The following is a description of a gene set: studied in species Mus musculus from publication Rashi-Elkeles S, Elkon R, Weizman N, Linhart C, Amariglio N, Sternberg G, Rechavi G, Barzilai A, Shamir R, Shiloh Y (PMID 16314843) Mouse Gene Set: RASHI_RESPONSE_TO_IONIZING_RADIATION_5 The ATM protein kinase, functionally missing in patients with the human genetic disorder ataxia-telangiectasia, is a master regulator of the cellular network induced by DNA double-strand breaks. The ATM gene is also frequently mutated in sporadic cancers of lymphoid origin. Here, we applied a functional genomics approach that combined gene expression profiling and computational promoter analysis to obtain global dissection of the transcriptional response to ionizing radiation in murine lymphoid tissue. Cluster analysis revealed a prominent pattern characterizing dozens of genes whose response to irradiation was Atm-dependent. Computational analysis identified significant enrichment of the binding site signatures of NF-kappaB and p53 among promoters of these genes, pointing to the major role of these two transcription factors in mediating the Atm-dependent transcriptional response in the irradiated lymphoid tissue. Examination of the response showed that pro- and antiapoptotic signals were simultaneously induced, with the proapoptotic pathway mediated by p53 targets, and the prosurvival pathway by NF-kappaB targets. These findings further elucidate the molecular network induced by IR, point to novel putative NF-kappaB targets, and suggest a mechanistic model for cellular balancing between pro- and antiapoptotic signals induced by IR in lymphoid tissues, which has implications for cancer management. The emerging model suggests that restoring the p53-mediated apoptotic arm while blocking the NF-kappaB-mediated prosurvival arm could effectively increase the radiosensitivity of lymphoid tumors. Cluster 5: early responding genes activated in ATM deficient but not in the wild type tissues., and this is the list of marker genes: Dsg2, Krt12, Eri2, Plk1, Mrpl17, Ap5s1, Serpine1, Ddx41, Nfia, Pik3r1, R3hdm1, Rxylt1, Fam53a, Smarcc1, Thbs2, Uchl5, Prlr, Usp7, Exosc8, Inhbc, Gas7, Txnrd2 (NCBI Gene Id 26462), Snx17, Smr2, Cib1, Tomm34, Atp13a3, P4hb, Map3k7, Map4k4, Crk, Ksr1, Glns-ps1, Deaf1, Surf6, Zbtb47, Atn1, Tcf20, Ppp1r3c, Cyp2c40, Vamp2, Emcn, Krtap6-2 (keratin associated protein 6-2), Epb41, Igll1, Col14a1, Inhba, Zfp30, Dnajc5, Cd93, Taf1b, Ncoa2, Herc2, Gadd45g, Gstm3, Dnmt3a, Larp7, Esyt3, Acbd6, Gipc2, Hsdl2, Zbtb14, Grb10, Cyp2a12, Galt, Shmt1, Cyth3, Eef1a2, Invs, Klf13, Pakap, Tomm6, Sh3bp5, Chtf8, Nacc2, Pcsk5, F7, Or13e8, Zfp787, Tmem229b, Rcc1, Pelo, Pex5, Dlat, Col13a1, Serpinb9e, Pax1, Stc2 (NCBI Gene Id 20857), Brip1os, Tmem170, Cd180, Dpt, Csnk2a1, Sh3gl3, Nfix, F5, Gsta4, Gpr33, Kcnj8, Cdc6, F2rl1, Cpox, Hmgcl, Tdo2, Naa40, Map3k4, Rnf7, Slmap (NCBI Gene Id 83997), Spata6, Cnot6l, Eif2ak2, Rap2b, Pak3, Epha4, Dnajb4, Dnajb2, Bcas2, Vhl, Frat1, Llgl2, Rnf225, Evi5, Fastk (NCBI Gene Id 66587), Dab2ip, Adora2a, Anp32a, Etfbkmt, Tfap2a, Fam118b (family with sequence similarity 118, member B), Casp8, Iqgap3, Bmpr1a, Dppa4, Pde8a, Chaf1b, Prepl, Cfhr1, Urm1, Ang